The following is a description of a gene set: Human Gene Set: HP_PROGRESSIVE_NEUROLOGIC_DETERIORATION studied in species Homo sapiens Progressive neurologic deterioration, and this is the list of marker genes: TIMMDC1, GLB1, RRM2B, GALC (galactosylceramidase), SDHAF1, SUMF1, HEXB, VCP, HSD17B10, PTS, MECP2, PMPCA, SYNJ1, SLC13A3, HIBCH, KCTD7, RNU4ATAC, ALDH18A1, IDUA, PDGFRB, BSCL2, TREX1, QDPR, CACNA1A, CYP27A1, CERS1, RAB27A, MICOS13, ERCC6, NDUFA6, ERCC8, EPM2A, GRN, SDHD, HEPACAM, PSAP, TINF2, NAGLU, ARSA, LRPPRC, MCOLN1, GCH1, EIF2B5, POLG, SDHB, ATP1A3, CTNS, CNTNAP2, NHLRC1, CYC1, MTFMT, ATP1A2, HNF4A (hepatocyte nuclear factor 4 alpha), SLC1A3, KARS1, ITM2B, SDHA, GBA1, SLC39A14